Given this list of marker genes ZNF114, ADAMTS4, SULT1C4 (sulfotransferase family 1C member 4), LINC01744, ACTE1P, FERMT2, LINC02078, FYB1, VWF, LINC01205, GNRHR2, ZFP42, MCMDC2, SYCP2 (NCBI Gene Id 10388, synaptonemal complex protein 2), GRM6, GAN, CLEC14A, PXDC1, ZNF606-AS1, RNF212, DCN, HAND2-AS1, KLRD1, ST8SIA1, FGD5P1, IGFBP5, LEMD1-AS1, LINC01448, GABRB2, ANTXR1, NOS1, SMIM17, MPDZ, IL10, RYR2, DEFA4, ACBD7, BNC2, SLC36A2, LRRN1, MNDA, DSC3, SPACA6-AS1, VIPR2 (NCBI Gene Id 94613), SYNPO2, MUC19, PTGIS, DNAH5, ARGFX, LINC02444, KCNMB4, ANKRD45, FZD4 (NCBI Gene Id 8322), CEACAM22P, C1S, AZU1, KDR, here is a description of the gene set: Human Gene Set: GAO_LARGE_INTESTINE_ADULT_CG_GOBLET_CELL_SUBTYPE_2 species: Homo sapiens from publication Gao S, Yan L, Wang R, Li J, Yong J, Zhou X, Wei Y, Wu X, Wang X, Fan X, Yan J, Zhi X, Gao Y, Guo H, Jin X, Wang W, Mao Y, Wang F, Wen L, Fu W, Ge H, Qiao J, Tang F (PMID 29802404)